The following is a description of a gene set: species: Homo sapiens Abnormality of the hepatic vasculature An abnormality of the hepatic vasculature. Human Gene Set: HP_ABNORMALITY_OF_THE_HEPATIC_VASCULATURE, and this is the list of marker genes: ENG, GNB2, GPR35 (NCBI Gene Id 2859), ELN, ACVRL1, TULP3, GBE1, ALMS1, MMEL1, PSMB9, RECQL4, CC2D2A, SHPK, DCDC2, POT1, GBA1, NAF1, RNU7-1, SP110, SRSF2, NOTCH1, CALR, SOX10, MPI, SEMA4D, MLXIPL, ZFYVE19, MET (MET proto-oncogene, receptor tyrosine kinase), IFT56, SMAD4, F5, CTNNB1, PIEZO1, MPL, TET2, ACTG2 (actin gamma 2, smooth muscle), ADA2, SCARB2, ITCH, TJP2, GDF2, RUNX1, ASXL1, CBL, MED12 (NCBI Gene Id 9968), LIPA, FARSB, CORIN, CLDN1, NEUROG3, IRF5, PRIM1, DOCK6, SERPINC1, BMP6, SLC4A1, INPP5E, SPIB, EOGT, STN1, GIMAP5 (GTPase, IMAP family member 5), UBR1, TNFSF15, FLT1, RBPJ, ABCD3, TCF4, KCNN4, DLL4, PKHD1, TNPO3, TREX1, RPGRIP1L, POU2AF1, NPHP3, HLA-DRB1, SLC30A10, IL12A (interleukin 12A), STOX1, JAK2, IL12RB1, TMEM67, KIF20A, GLIS3, BTNL2, MST1, HFE, KRIT1, DGUOK, DZIP1L, PIGM, KIF12 (NCBI Gene Id 113220), ARHGAP31